Given this list of marker genes UNKL, TCL1A, SDC2, IL7R (interleukin 7 receptor), RUBCNL, UNC5D, LPAR6, CCDC186, GBP2, FCER2, IGLJ3, DEFA1, IFIT1, KIAA0753, HLA-DPB1, MED12L, CCL7, OAS1, MECP2, CARD16, POU2F2, HVCN1, SPIB, OAS3, IGHM, HLA-A, CD3D, IL2RB, RNF31, KCTD12, MX1, HLA-DPA1, CTSL, UNC79 (unc-79 homolog, NALCN channel complex subunit), CNRIP1, TREM1, GBP1, AQP9, RRP15, TRDD3, STAT1, PNMA8A, BLNK, IGKC, FCRL1, IL3RA, TXLNGY, CD14, NRIP2, CD200, IGHG3, KCNQ5 (potassium voltage-gated channel subfamily Q member 5), IGLL1, NLRC5, CAMK4, LGALS3BP, IFT70A, CD2, SLC24A3, MARCHF1, IFITM1, FCRLA, TNFRSF25, CD86, HLA-DQB1, HLA-DMA, FPR1, LIMD2, ADGRE2, CD37, ZNF436, HBA2, C3orf36, MAL, GNLY, BANK1 (B cell scaffold protein with ankyrin repeats 1), FCRL2, UBE2L6, HLA-DRA, TAP1, PLCL2, IFITM3, TNFSF10, IFI44L, UNC13B, MS4A1, CSF3, BST2, CD27, HLA-DMB, SERPINA5, P2RY10, CD79B, FOXP1, SLC22A23, FAM53B, CD5 (CD5 molecule), CYP1B1, RCSD1, ADAM19, RSAD2, CEBPD, CD79A, THBS1 (NCBI Gene Id 7057), KLRK1, UTY, TNFAIP6, HLA-C, PELI1, SPON2, IFI27, CTLA4, UCP1, DBP, CCL18, APOL3, HLA-DQA1, TTLL2 (tubulin tyrosine ligase like 2), TXNIP, MST1L, PARP14, IFI35, RAPGEF6, CD74, PRMT3, STK31, PPP1R16B, AXIN1, LGMN, CACNG4, ISG15, NEK11, HELZ2, CXCL9, SAMSN1, GSTM2, ABTB1, DPEP2, here is a description of the gene set: Human Gene Set: MODULE_436 studied in species Homo sapiens Genes in the cancer module 436.